The following is a description of a gene set: Any process that modulates the rate, frequency, or extent of chromosome condensation, the progressive compaction of dispersed interphase chromatin into threadlike chromosomes prior to mitotic or meiotic nuclear division, or during apoptosis, in eukaryotic cells. species: Mus musculus Mouse Gene Set: GOBP_REGULATION_OF_CHROMOSOME_CONDENSATION, and this is the list of marker genes: Ncapg2, Ncapg (non-SMC condensin I complex, subunit G), Mcph1, Ncaph, Baz1b, H3f3b, Ncapd2, Smc4, Smarca5, Ncapd3, Ncaph2, Smc2, Ccnb1, H3f3a